The following is a description of a gene set: Autophagy can be a selective process where specific cargo (organelles/proteins) are targetted to degradation in the lysosome. In general, selective autophagy is initiated when a cellular signal tags the cargo organelle for degradation. Subsequently, cargo recognition proteins detect and recruit the organelle to interact directly or indirectly with Atg proteins forming the phagophore. The next steps involve formation of the autophagosome and fusion with the lysosome for degradation. Depending upon the organelle, different molecules are used to for the autophagy mechanism (Andling AL et al. 2017). Consequently, the different mechanisms are known by the organelle degraded such as mitophagy for mitochondia, lipophagy for lipid droplets, pexophagy for peroxisomes and aggrephagy for aggregated proteins. studied in species Homo sapiens part of: Macroautophagy Reactome Pathway: Selective autophagy, and this is the list of marker genes: TUBA3D, UBC, VDAC1, PARK7, UBE2V1, PEX5, ARL13B, UBA52, TBK1, CETN1, RPS27A, UBE2D3, DYNC1LI1, TOMM5, UBB, TUBB4A, UBE2L3, UBE2N, TUBB6, VCP, TOMM70, FUNDC1 (NCBI Gene Id 139341), ATG5, EPAS1, MFN2, TUBB8, PRKN, DYNC1I1, PCNT, ATM, ULK1, DYNC1I2, SRC (SRC proto-oncogene, non-receptor tyrosine kinase), PRKAG2, TOMM6, TUBAL3, MTERF3, USP30, PLIN3, VIM, ATG9A, HSP90AA1, TUBA1A, CSNK2B, DYNLL2, TUBA3E, TOMM40, TUBA4B, DYNC1LI2, SQSTM1, TUBB2B, DYNC1H1, CSNK2A2, TUBB8B, HSF1, PRKAA2, VDAC3, UBE2D2, ATG12, TOMM7, NBR1, PRKAG1, PINK1, OPTN, TUBB3, TUBB4B, CSNK2A1, DYNLL1, TOMM20, PLIN2, PRKAB2, VDAC2, HDAC6, CFTR, TUBB2A, MAP1LC3A, TUBA8, PRKAB1 (NCBI Gene Id 5564), IFT88, HSPA8, TOMM22, TUBA1B, MFN1, TUBA4A, PGAM5, TUBB1, PRKAG3, MAP1LC3B (NCBI Gene Id 81631), TUBA3C, TUBA1C